Given this list of marker genes CYP19A1, here is a description of the gene set: Aromatase (CYP19A1) catalyses the conversion of androstenedione (ANDST) to estrone (E1). Defects in CYP19A1 can cause aromatase excess syndrome (AEXS; MIM:139300) and aromatase deficiency (AROD; MIM:613546). Affected individuals cannot synthesise endogenous estrogens. In females the lack of estrogen leads to pseudohermaphroditism and progressive virilization at puberty, whereas in males pubertal development is normal. Reactome Pathway: Defective CYP19A1 causes AEXS part of: Metabolic disorders of biological oxidation enzymes species: Homo sapiens